The following is a description of a gene set: studied in species Homo sapiens The aggregation, arrangement and bonding together of a set of components to form the spindle that contributes to the process of meiosis. Human Gene Set: GOBP_MEIOTIC_SPINDLE_ASSEMBLY, and this is the list of marker genes: AURKA, DCAF13, NDC80, DDB1, PTEN, ASPM (NCBI Gene Id 93990), SEPTIN1, GOLGA2, TUBB8, CCNB2, WASHC5, SKA2, FBXO5, SKA1, SKA3